Given this list of marker genes Prkd3, Prkar2b (protein kinase, cAMP dependent regulatory, type II beta), Akap1, Akap4, Rras, Gnb5, Adcy7, Calm1, Prkcd, Adcy2, Gng3, Akap13, Slc9a1, Adcy9, Gnas, Akap5, Itpr1, Prkcb, Prkacb, Prkd1, Pde1c (NCBI Gene Id 18575), Gng12, Pde8b, Pde7b, Gnao1, Gng11, Gnai3, Prkca (protein kinase C, alpha), Plcb3, Gnb3, Prkar1a, Adcy1, Akap12, Gngt1, Gnb1, Prkcq, Gnaq (guanine nucleotide binding protein, alpha q polypeptide), Akap10, Akap3, Prkcg, Kras, Hras (Harvey rat sarcoma virus oncogene), Gna14, Prkce, Pde7a, Gng10, Gng8, Gna15, Gnai2, Prkaca, Gng5, Adcy3, Gngt2, Adcy5, Ppp3cc, Prkar1b, Prkar2a, Adcy6, Rhoa, Gnal, Gnai1, Gng4, Akap6, Gnaz, Pde4a, Gna12, Akap7, Pde4c, Prkch, Prkci (NCBI Gene Id 99620), Kcnj3, Akap11, Adcy4, Pde8a, Gng13, Gna11, Nras, Pde1b (NCBI Gene Id 18574), Pde4b, Arhgef1, Akap9, Gna13, Pde1a, Pde4d, Ppp3ca, Gng7, Akap8, Adcy8, Prkcz, here is a description of the gene set: G protein signaling pathways Mouse Gene Set: WP_G_PROTEIN_SIGNALING_PATHWAYS species: Mus musculus